Given this list of marker genes Hes5, Osr1, Nodal, Irx3, Pbx1, Grem1, Hoxc11, Hoxd9, Hoxd11, Pbx2, Dlx1, Dll1, Hoxc9, Cyp26b1, Lrp4, Irx2, Hoxa9, Gli1, Gli2, Six3, Hoxd10, En1, Sp8, Fgf10, Hoxb9 (NCBI Gene Id 15417), Trp63, Dlx2, Hoxa10, Hoxc10, Chsy1, Hoxa11, Apc, Gli3, Irx1, Aldh1a2, Wnt8a, Ctnnb1, here is a description of the gene set: The regionalization process in which specific areas of cell differentiation are determined along a proximal/distal axis. The proximal/distal axis is defined by a line that runs from main body (proximal end) of an organism outward (distal end). species: Mus musculus Mouse Gene Set: GOBP_PROXIMAL_DISTAL_PATTERN_FORMATION